The following is a description of a gene set: Human Gene Set: MODULE_160 studied in species Homo sapiens tRNA synthesis., and this is the list of marker genes: IARS1, HARS2, YARS1, KARS1, AARS1, NARS1, EPRS1, QARS1, TARS1, GARS1, SARS1, KHSRP, VARS1, CARS1, HARS1